The following is a description of a gene set: Human Gene Set: chr12p12 studied in species Homo sapiens, and this is the list of marker genes: RPL7P6, MGST1, LINC02955, RN7SKP262, PTPRO, PLCZ1, RN7SL67P, SKP1P2, GOLT1B, PSMC1P9, C2CD5-AS1, RNU6-251P (RNA, U6 small nuclear 251, pseudogene), RECQL, RPS27P22, ETNK1-DT, RNU4-67P, SLCO1B1, CAPZA3, TIMM17BP1, RERG, RNU1-146P, PYROXD1, SLCO1B3, BORCS8P1, LINC02468, RN7SL459P, PDE6H, C2CD5, PSMC1P8, BRI3P2, SUPT16HP1, LDHB, SOX5-AS1, WBP11, DNAI7 (NCBI Gene Id 55259), STRAP, H2AJ, RASSF8, RERG-IT1, MGP, SMCO3, SPX, SLC15A5, MIR4302, FAM133GP, GUCY2C, RASSF8-AS1, METTL8P1, LINC01489, CENPUP2, ETNK1, RERGL, UBE2L2, RN7SL38P, MIR3974 (microRNA 3974), SOX5, LMO3, TDGP1, LINC00477, SLCO1A2, KNOP1P1 (NCBI Gene Id 100129937), LMNTD1, RNU1-149P, MIR920, TCP1P3, PDE3A-AS1, ENSG00000256615, ENSG00000255745, IAPP, RNU6-837P, RPL7P40, RERG-AS1, LRRC34P1, EGLN3P1, CMAS, RNU6-254P, DERA, LINC02909 (long intergenic non-protein coding RNA 2909), PIK3C2G, PLEKHA5, ABCC9, LINC02378, ETFRF1, IRAG2, H4C16, PDE3A, ENSG00000256389, KRAS, PDCD5P1, EEF1A1P16, BCAT1, ARHGDIB, EEF1A1P4, TUBB4BP1, ERP27, SLCO1C1, GUCY2C-AS1, NDFIP1P1, LINC02566 (long intergenic non-protein coding RNA 2566), SLCO1B7, SSPN, AEBP2, GYS2, EPS8, C12orf60, SLCO1B3-SLCO1B7, ST8SIA1, SULT6B2P, ART4, BHLHE41 (NCBI Gene Id 79365), ELOCP31, KCNJ8, ZKSCAN7P1